The following is a description of a gene set: studied in species Homo sapiens A multienzyme, heterooligomeric complex involved in dolichyl-linked oligosaccharide synthesis. In yeast the complex is composed of Alg7p, which catalyzes the first step (GlcNAc1-PP-Dol from dolichol-phosphate and UDP-GlcNAc), and Alg13p plus Alg14p, the catalytic and anchoring subunits respectively, which together catalyze the second step (GlcNAc2-PP-dolichol from GlcNAc1-PP-Dol and UDP-GlcNAc) of dolichyl-linked oligosaccharide synthesis. Human Gene Set: GOCC_UDP_N_ACETYLGLUCOSAMINE_TRANSFERASE_COMPLEX, and this is the list of marker genes: UGT3A2, EXT2, UGT3A1, ALG13, ALG14